The following is a description of a gene set: Human Gene Set: GOBP_INTERLEUKIN_23_PRODUCTION studied in species Homo sapiens The appearance of interleukin-23 due to biosynthesis or secretion following a cellular stimulus, resulting in an increase in its intracellular or extracellular levels., and this is the list of marker genes: PLCG2 (NCBI Gene Id 5336), TLR4, IL17RA, MYD88, TGFB1, IFNG, CSF2, RAC1, IL17A, CLEC7A